The following is a description of a gene set: Genes in the cancer module 257. studied in species Homo sapiens Human Gene Set: MODULE_257, and this is the list of marker genes: VAMP2, LIMK1, ABCA7, CDC42EP1 (CDC42 effector protein 1), SH3GLB2, STAT5B, MYH7B, PLK4, FAM168A, RTKN (rhotekin), MED9, APLP2, SNRNP70, EXTL3, OXR1, PMPCA, MEF2C, SLC20A1, TP53INP2, SSBP3, ECE1, PLXND1, DLGAP4, MDH2, HMG20B, TRA2A, HPCA, TGOLN2, SHC1, ERF, CHAF1A, HDAC7, CLEC3B, NCAPH, CAMSAP3, ARL4C, CPSF7, ELK3, LRRC61, FAT1, EDC3, GABRG2, FKBP8, SRRT, MEF2D, CHPF, NAGLU, GNS, MAP4K2, TNRC6A, MFSD9, RAB35, HDAC10, EHD1, SEC14L1, RBM14, WDR37, TSKU, DNAJC4, MUTYH, KMT2D, DNAJC3, SLC35F6, SLC7A2, PPIP5K2, VAV2, GLE1, LRRC8A, TLE3 (NCBI Gene Id 7090), VPS9D1, UBTD1, ACAD10, IFT43, TELO2, MMP15, DGKZ, OAZ2, SLC35C1, ELL, MGAT1, PGAM2, CAD, SEC61A1, TCF7, TBC1D1, EPS8L2, URGCP, TNPO2 (NCBI Gene Id 80048), ACTN3, YIF1A, USP5 (ubiquitin specific peptidase 5), AKT1, TBCK, ARFIP2, CD93, STARD3, PPM1F, CA2, EEF2, KANSL1 (KAT8 regulatory NSL complex subunit 1), MTA1, ZDHHC8, MCAM, GRK2, VPS39, DDX17, DCTPP1, USHBP1, FBF1, INPPL1, GPS1, SKI, CABYR, SNRPA, FZR1, ZNF3, TAF6L, GYPC, CTSD, TSC2, IMPDH1, PIGQ, DGCR8, ATP11A, RARA, LIMD1, PTTG1IP, GABRB1, CD276, TLE4, PPP1R15A, CALD1, GRK5, ATXN2, ANAPC2, N4BP2, LRP1, ASB5, MKRN1, RAB11B, PNPLA2, PRPF8, PLD3, HSPA1L, PFKL, NUMA1, HEG1 (NCBI Gene Id 57493), AKT2 (NCBI Gene Id 208), CLSTN1, LRP5, PACSIN2, LITAF, IDS, RNF40, CCNL2, BLTP2